The following is a description of a gene set: Genes up-regulated in polarizing CD4 Th17 cells: wildtype vs RORC knockout treated with digoxin. CD4+ T helper lymphocytes that express interleukin-17 (Th17 cells) have critical roles in mouse models of autoimmunity, and there is mounting evidence that they also influence inflammatory processes in humans. Genome-wide association studies in humans have linked genes involved in Th17 cell differentiation and function with susceptibility to Crohn’s disease, rheumatoid arthritis, and psoriasis1-3. Thus, the pathway towards differentiation of Th17 cells and, perhaps, of related innate lymphoid cells with similar effector functions4, 5, is an attractive target for therapeutic applications. Mouse and human Th17 cells are distinguished by expression of the retinoic acid receptor-related orphan nuclear receptor RORγt, which is required for induction of IL-17 transcription and for the manifestation of Th17-dependent autoimmune disease in mice6. By performing a chemical screen with an insect cell-based reporter system, we identified the cardiac glycoside digoxin as a specific inhibitor of RORγt transcriptional activity. Digoxin inhibited murine Th17 cell differentiation without affecting differentiation of other T cell lineages and was effective in delaying the onset and reducing the severity of autoimmune disease in mice. At high concentrations, digoxin is toxic for human cells, but non-toxic synthetic derivatives, 20,22-dihydrodigoxin-21,23-diol (Dig(dhd)) and digoxin-21-salicylidene (Dig(sal)), specifically inhibited induction of IL-17 in human CD4+ T cells. Using these small molecule compounds, we demonstrated that RORγt is imporant for the maintenance of IL-17 expression in mouse and human effector T cells. These data suggest that derivatives of digoxin can be used as chemical probes for development of RORγt-targeted therapeutic agents that attenuate inflammatory lymphocyte function and autoimmune disease. from publication Huh JR, Leung MW, Huang P, Ryan DA, Krout MR, Malapaka RR, Chow J, Manel N, Ciofani M, Kim SV, Cuesta A, Santori FR, Lafaille JJ, Xu HE, Gin DY, Rastinejad F, Littman DR (PMID 21441909) Human Gene Set: GSE27241_WT_CTRL_VS_DIGOXIN_TREATED_RORGT_KO_CD4_TCELL_IN_TH17_POLARIZING_CONDITIONS_UP species: Homo sapiens, and this is the list of marker genes: CD2, MAP2K5, VPS37B, LRATD2, KTN1, EGLN3, HMG20A, MYH10, SH3KBP1, SUSD1, ACSL1, ADD3, PIK3CG, MBOAT1, TMEM63A, GPR25, PHLPP1, MACROH2A1, RSPO2, TOX2 (NCBI Gene Id 84969), GCC2, EEIG1, SEMA4G, CD200, FAM117A, PPP1R13B, AMPD1, GPR155, CLIP1, CYBRD1, L3MBTL3, ANK1, CMYA5, IL17RB, CNNM1, PPM1E, CHL1, SRGAP3, RHOBTB2 (Rho related BTB domain containing 2), GK5, SLC35D1, CRACR2A, P4HA2, TLE4, STMN1, ST6GAL1, EPAS1 (NCBI Gene Id 2034), PTPN14, DAP, CERS6, BLTP3B, RAPGEF4, TRIM24, TRAM1, PKM, RAPGEF6, CYP8B1, XYLT2, SLC16A10, ST8SIA1, TSSK2, CD163L1, MALT1, FMNL3, ATF6, HSD17B3, FILIP1L, CHD7, EEIG2, CFLAR, ALOX5AP (NCBI Gene Id 241), KLHL40, KLHL25 (NCBI Gene Id 64410), HERC3, CHD3, PPIP5K1, PHF14, PCYT1A (NCBI Gene Id 5130), ABI2, PDZD4, PRKCQ, LPXN, WDR33, RBL2, P2RX7, RABGEF1, IL18R1, LRRC7, IQGAP2, RTF1, CDKAL1, PWWP3B, LMO4, RPS6KA1, SLA, HOMER1, SELL, CCNO, RGS10, JARID2, TMEM231, SLC2A4 (solute carrier family 2 member 4), SLC37A3, KCNG1, AP1S2, SHC4, NDRG1, CDK5R1, MAP3K12, SMAD5, SLCO3A1, CAMK2D (calcium/calmodulin dependent protein kinase II delta), ARHGAP26 (Rho GTPase activating protein 26), CDC14B, DUSP7, GATA3, MYO1F, PIK3CD, GFPT1 (NCBI Gene Id 2673), BTLA, JMJD1C, IQCH, CCDC141, EPS15, CDR2, ACOT4, PRM1, KIF4B, ARAP2, RPGRIP1L, USP37, ALDH18A1, SPATS2, CD5 (NCBI Gene Id 921), ADSS1, GSN, VAV3, CD6, RFC1, GXYLT1, ANKRD27 (NCBI Gene Id 84079), ITGAM, HIVEP3, EDARADD, ITGB6, LZIC, ARHGAP29, HDAC5, KMO, ACTN2, TRIM26, JAKMIP1, BBC3 (NCBI Gene Id 27113), CHDH, AKT3, ATCAY, GALE, SH3BP5, ABL2 (ABL proto-oncogene 2, non-receptor tyrosine kinase), WDR59, TEX9, IFNGR1, PER1, ZSCAN20, RNF213, CORO2B (NCBI Gene Id 10391), GFRA1, GPR146, PPM1L, SEMA4C, IRF8, TRIO